The following is a description of a gene set: studied in species Homo sapiens from publication Xie X, Lu J, Kulbokas EJ, Golub TR, Mootha V, Lindblad-Toh K, Lander ES, Kellis M (PMID 15735639) Comprehensive identification of all functional elements encoded in the human genome is a fundamental need in biomedical research. Here, we present a comparative analysis of the human, mouse, rat and dog genomes to create a systematic catalogue of common regulatory motifs in promoters and 3' untranslated regions (3' UTRs). The promoter analysis yields 174 candidate motifs, including most previously known transcription-factor binding sites and 105 new motifs. The 3'-UTR analysis yields 106 motifs likely to be involved in post-transcriptional regulation. Nearly one-half are associated with microRNAs (miRNAs), leading to the discovery of many new miRNA genes and their likely target genes. Our results suggest that previous estimates of the number of human miRNA genes were low, and that miRNAs regulate at least 20% of human genes. The overall results provide a systematic view of gene regulation in the human, which will be refined as additional mammalian genomes become available. Human Gene Set: TTCNRGNNNNTTC_HSF_Q6 Genes having at least one occurrence of the highly conserved motif M141 TTCNRGNNNNTTC in the regions spanning 4 kb centered on their transcription starting sites. This matches the transcription factor binding site V$HSF_Q6 (v7.4 TRANSFAC)., and this is the list of marker genes: EGR3, TMEM35A, PMP22, PHF6, CYP46A1, EIF4A2, PPID, CEPT1, ZNF462 (NCBI Gene Id 84452), CNGB3, TSPAN6, CCT4, HSPA1A, XPO1, HOXA2, LHX1, HSPB2, UBE2E3, MXD4, UBE2B, UNC45B, FGF10, TFCP2L1, TNFAIP8, HSPH1, KRIT1, SPIN1, THAP10, DDX17, MOSMO, SPTY2D1, AHSA2P, HSPA1L, ZNF800, REXO4, HSPA8, NNAT, HIKESHI, YWHAE, SEMA6C, UPF2, C1RL, RCC2, CNTN6, HNRNPA2B1 (heterogeneous nuclear ribonucleoprotein A2/B1), ACBD3, GJB2, MORF4L2, FKBP4, RSPO2, NODAL, STK40, PARP16, YWHAG, SLC15A2, HSP90AB1, PDZRN4, HSPA1B, SERPINH1, HSPD1, NECTIN1, GNAL, DNAJB5, ECEL1, ATP2C1, NEUROG1, ST13, ZBTB32, STX4, CRYGB, LMNB1, TBPL1, JMJD6, EDN1, CBX3, WNK4, PAFAH1B1, MUSK, TNXB, MECOM, LRP8, ZNF148, PWWP3B, SESN2, CDKL5, STARD8, HSPA4L, STIP1, GPR162, FOXP1, RAB39A, JAK1, CRIPTO, ZBTB37, VIPAS39, NUDT4 (nudix hydrolase 4), UBB, GPR50, NR2F1, LRRC2 (NCBI Gene Id 82953), NFATC3, MACROH2A2, LRRC49, CANX, GPR4, DNAJA1, AHSA1, PTOV1, MYL1, XPNPEP3, TWIST1, CRYAB, CACNA1G, JPT2, NUTF2, RANGAP1, RTN1, EIF4A1, DAZL, CCT7, USPL1, PRADC1, ABHD2, VEGFA, JOSD2, DCSTAMP, MYRF, RORA, HSPE1, MAT2A, ZMIZ1, MKNK2, CHORDC1, ACOT7, FEZF2, C12orf50, UBQLN1, INHBB, FOSB, SEL1L3, MAP6, GATA6, PURA, DMRTB1, NR4A3, LRRN4CL, CDK17, DPYSL2, ZNF428, RBM6, ERLIN2, NR2E1, CCT8, STAG2, E2F3